Given this list of marker genes SLC32A1, SLC18A2, VAMP2, HSPA8, GAD2, DNAJC5, GAD1, SLC18A1, SLC18A3, SYT1, SLC17A7, RAB3A, here is a description of the gene set: species: Homo sapiens A clathrin-sculpted lipid bilayer membrane-enclosed vesicle after clathrin release. Human Gene Set: GOCC_CLATHRIN_SCULPTED_VESICLE